The following is a description of a gene set: Failure to thrive in infancy Human Gene Set: HP_FAILURE_TO_THRIVE_IN_INFANCY species: Homo sapiens, and this is the list of marker genes: SETD2, NPAP1, GDNF, ERBB2, ECE1, VPS37D, HADHB, ABCC6, PUS3, RECQL4, ERBB3, SCNN1B, TRAPPC11, VPS13B, SP110, CLIP2, RAI1, YARS1 (tyrosyl-tRNA synthetase 1), FOXP3 (forkhead box P3), PSMB10, OTULIN, SLC30A9, BAZ1B, MCCC1, PWAR1, NRTN, MS4A1, FLII, JAK3, ABCD1, COG1, MKRN3, DYRK1A, PSMD12, FOXP1, TOM1, TNFSF12, GTF2IRD2, GTF2I, TMEM270, TKFC, IRF2BP2, PTPN11, BUD23, HPDL, MYOD1, CSF2RB, RAC2, STX1A (NCBI Gene Id 6804), HBB, COPB2, NFKB1, CRELD1 (cysteine rich with EGF like domains 1), KRAS, SNORD115-1, LTC4S, NDUFA4, FDFT1, ICOS, SCNN1G, ELN, PYGL, MVK, NFKB2, SPOP, SLC35A2, ITCH (NCBI Gene Id 83737), COG4, CD19, METTL27, FKBP6, EDN3, GMPPA, CSF2RA, DEAF1, ERCC1, AAAS, GTF2IRD1, SEMA3D, SREBF1, MCCC2, BRAF, CTNS, TK2, TNFRSF13B, DNAJC30, SETBP1, FIG4, HERC2, ENPP1, UNC80, HADHA, NCF1, NSMCE3, BPTF, SCNN1A, COX5A, RFC2, POLA1, CARS1, LIMK1, DIAPH1, SLC39A8, CD81, PSAT1, CR2, SON, KIF15, SNORD116-1, MAGEL2, SLC25A13, ATP7A, MLXIPL, SLC16A2, HRAS, PWRN1, IL1RN, SEMA3C, SMO, EIF4H, EDNRB, TBL2, NR0B1, TGFB3, RET (NCBI Gene Id 5979), CD96, IL2RA, TNFRSF13C, MAP2K1, MAP2K2, IQSEC2, FGFR1